Given this list of marker genes RPA1, RAD51, TOPBP1, TBP, TRIP13, REC8, MORC1, CTCF, SMARCB1, SPAG8, DAZAP1, H2AX, ADAD1, TESMIN, ANKRD37, TERF2, HSPA2, GTF2A1L, ACTL7A, RAN, TAF4, ZBTB16, SMAD5, SMAD1, TAF10, CCNH, TCFL5, TAF3, PATZ1, ZFPM2, SPATA24, MARCKS, TAF7, H2AC1, ACTRT3, HMGA2, TOP1, HMGN1, SMARCC1, BRCA1, CDK2, H2BC1, PCNA, TRIM24, MLH1, PRM2, KDM3A, CDK7, SLC2A1, LIMK1, TERF2IP, KPNA7, TSN, TBPL1, AURKA (aurora kinase A), DMRT1, YAP1 (NCBI Gene Id 10413), TOP2A, SYCP2L, SYCP1, MAEL, MLH3, STPG4, DNMT1, TNP1, ZMYND15, AIRE, GTF2B, TBPL2, KPNA4, TP53, H1-9P, here is a description of the gene set: The nucleus of a germ cell, a reproductive cell in multicellular organisms. Human Gene Set: GOCC_GERM_CELL_NUCLEUS studied in species Homo sapiens